Given this list of marker genes Stxbp1, Syt4, Unc13b, Snap25, Cadps, P2rx7, Rab3a, Syt6, Rims1, Syt10, Stxbp3, Unc13a, Stxbp2, here is a description of the gene set: Mouse Gene Set: GOBP_NEURONAL_DENSE_CORE_VESICLE_EXOCYTOSIS species: Mus musculus The secretion of molecules (e.g. neuropeptides, insulin-related peptides or neuromodulators such as serotonin and dopamine) contained within a neuronal dense core vesicle by fusion of the granule with the plasma membrane of a neuron in response to increased cytosolic calcium levels.